Given this list of marker genes ISYNA1, CUEDC2, GSTO1, CCNB2, SLC44A3 (solute carrier family 44 member 3), LDLR, PLBD1, AATK, LCN2, SLC39A1, MRPL41, TCF4, RAB31, MKI67, MICOS10, PDZRN3, SH3RF1, PLXND1, PCYT2, AGGF1, RPLP1, KIAA1217, FZD3, PKM, CIITA, SLC25A4 (solute carrier family 25 member 4), UBL5, SEM1, CLU, ZDHHC14, KIF1C, XIST, APOA2, SSX2IP, SLC41A3 (NCBI Gene Id 54946), ZSCAN26, MBP, CCL24, CDH9, HMGCS1, MBTD1, CCL17, CST9L, GTF2B, TLX1, NDUFA11, NDUFV2, GOT2, ZYX, PTGFR, MAFB, ZFHX3, PTGER2, SLC25A17, MRPL33, TRAT1, PLCG2, HEPH, ANXA3, MYL6, L1CAM, APOBR, ALDH9A1, NADK, PIP, NOP10, SCARA5, TXNDC16, MYOZ3, CNTFR, MAP3K11, CTDSPL, POLD1, CEBPZOS, ACOX1, STARD4, RAD17, TKT, ST6GAL1, PELI1, ARPP19, SNRPD2, ZNF689, MARCO, TMEM176A, HEPACAM2, TALDO1, PROS1, RPS9, KRT14, RIDA, SQLE, BAG1, TEP1, EIF3F, CLEC4A, EEF1D, PCDHB13, ALPK3, RAB3D, ARRB1, CDC42SE1, DBI, UCN, GPRC5D, SFXN3, TCF15, SUOX, DOCK5, DHCR24, CYSLTR1, RPL7A, ADRB3, TM2D3, MGST2 (microsomal glutathione S-transferase 2), NDST1, FUOM, LGALS4, S100A13, ATP5PB, WSB2, EIF3I, FDPS, ANAPC13, VWA8, PTRH2, SS18L2, MVD, COX6C, RAD51, SLITRK1, SLCO1B3, TMEM114, ANG, FNBP1, ESYT3, ASB14, ITFG1, CD9, RPS21 (NCBI Gene Id 6227), RPL23, SH3YL1, KGD4, LAMC2, THAP7, RPL26, MAN1A1, SLC6A12, RBFOX2, RPL22L1, GJA8, LDHA, CSNK1G2, CHD4, CEP89, GMNN, RPS4X, FOXC2, DAPK1, EPHA6, MRPL20, ANKH, JAK2, EGLN3, DXO, FASN, PGAM1, LARP7, SURF4, NANS, FUCA1, FCGR2A, FDFT1, SERPINF2, PAFAH2, ALDH1L1, ELOVL1, PPP6R2, MKNK2, CIB1, LRFN1, INTS6, NAA10, STOM, HELZ, UQCRC2, ERLEC1, RALBP1, KLF9 (KLF transcription factor 9), NCKAP1L, INTS3, GSTM3, EPS15, WNT6, CTDSP1, C3orf70, TMEM268, PSMB3, POP5, PCMTD2, here is a description of the gene set: Human Gene Set: GSE17721_PAM3CSK4_VS_GADIQUIMOD_24H_BMDC_UP studied in species Homo sapiens mouse primary BMDCs were stimulated with tlr ligands and gene expression changes were profiled on Affymetrix arrays Genes up-regulated in comparison of dendritic cells (DC) stimulated with Pam3Csk4 (TLR1/2 agonist) at 24 h versus DC cells stimulated with Gardiquimod (TLR7 agonist) at 24 h. from publication Amit I, Garber M, Chevrier N, Leite AP, Donner Y, Eisenhaure T, Guttman M, Grenier JK, Li W, Zuk O, Schubert LA, Birditt B, Shay T, Goren A, Zhang X, Smith Z, Deering R, McDonald RC, Cabili M, Bernstein BE, Rinn JL, Meissner A, Root DE, Hacohen N, Regev A (PMID 19729616)